Given this list of marker genes Pde6c, Pde1c, Pde6h, Pde9a, Pde1b (NCBI Gene Id 18574), Pde5a, Pde6a, Pde6g, Pde11a, Pde1a, Pde6b, here is a description of the gene set: studied in species Mus musculus Mouse Gene Set: GOMF_CALMODULIN_ACTIVATED_DUAL_SPECIFICITY_3_5_CYCLIC_GMP_3_5_CYCLIC_AMP_PHOSPHODIESTERASE_ACTIVITY Catalysis of the reactions: 3',5'-cyclic AMP + H2O = AMP + H+ and 3',5'-cyclic GMP + H2O = GMP + H+; this activity is activated by binding to calcium-bound calmodulin.